The following is a description of a gene set: Mouse Gene Set: GOBP_POSITIVE_REGULATION_OF_CALCIUM_MEDIATED_SIGNALING Any process that activates or increases the frequency, rate or extent of calcium-mediated signaling. studied in species Mus musculus, and this is the list of marker genes: Edn1, L1cam, Ptbp1, Pcp4, P2rx4, Clec7a, Pdgfrb, Ppp3cb, Chp2, Ramp3, Ptprc, Calcr, Erbb3, Cherp, Nmur1, Ncs1, Syk, Sppl3, Ppp3r1, Ada, Camta1, Cd8a, Ptprj, Tnf, Gpr62, Ncam1, Kdr, Ppp3ca, Ppp3cc, Nrg1, Prnp, Adora3, Exoc4, Slc9a1, Zap70, Htr2c, Ppp3r2, Fcer1a, Cib1, Grm5, Cdh13, Neurod2, App, Pdgfra, Trat1, Sco1, Negr1, Cd4, Car8, Ccl3, 3425401B19Rik, Cd3e, Plcg2, Lmcd1, Edn2, Itgal, Akap5, Akap6, Htt, Trem2, Hint1, Igf1, Lhcgr, Iapp (NCBI Gene Id 15874), Cd24a